The following is a description of a gene set: studied in species Homo sapiens Human Gene Set: GOBP_TRANSLATION The cellular metabolic process in which a protein is formed, using the sequence of a mature mRNA or circRNA molecule to specify the sequence of amino acids in a polypeptide chain. Translation is mediated by the ribosome, and begins with the formation of a ternary complex between aminoacylated initiator methionine tRNA, GTP, and initiation factor 2, which subsequently associates with the small subunit of the ribosome and an mRNA or circRNA. Translation ends with the release of a polypeptide chain from the ribosome., and this is the list of marker genes: MIR27A, WFS1, MRPL49, MIR133B, C8orf88, RPL21, MRPL21, RPL14, OXA1L, MRPS25, PML, MRPL20, MTG2, HBS1L, SMYD5, EIF2B1, TRIM71, CNOT7, FXR1, RPL36AL, MRPL40, CDKAL1, CYFIP1, RPL36, MRPL53, NARS2, EIF3E, MPV17L2, PTRH1, HNRNPU, MIR659, RPL4, RNF139, NCL, TRUB2, AJUBA, MRPL45, RNF14, MIR365A, IARS2, EIF3M, HEMK1, RPSA2, MRPL51, MIR221, KBTBD8, RPL37, CNOT8, LRRC47, BZW1, RPS6KA1, RPS10, CELF4, MIR24-1, FASTKD2, RPS28, SAYSD1, PDF, YARS2, RPS23, EIF2AK3 (eukaryotic translation initiation factor 2 alpha kinase 3), RPL8, SELENOT, EIF1AX, SYNCRIP (synaptotagmin binding cytoplasmic RNA interacting protein), MTPN, RPL39L, RBM4, DHX36 (DEAH-box helicase 36), FAU, PPP1CA, RBMS3, EIF3L, EPRS1, CPEB3, RPL26, EEF1G, MIR17, RPL27A, HRURF, EARS2, LINC01145, DHX33, RPS15, PARP16, MIR205, NAT10, CAPRIN2, MTRFR, MIR29A, PRMT1, RPL30, MRPS16, LARP4B, CDK5RAP3, BZW2, ALKBH5 (alkB homolog 5, RNA demethylase), SKIC8, EIF5B, RNF25, PPP1R15A, EIF2D, MIR128-1, RPL23, MRPL1, ZAR1, GTDC1, EIF2B3, RRBP1 (ribosome binding protein 1), MIR874, LSM14A, RPS29, MRPS31, CPEB1, GEMIN5, SCRIB, RPL37AP8, MTOR, MIR126, ALKBH3, RPUSD3, RPS20, TNF, APEH, RBM4B, CIRBP, MRPL52, FARSB, MRPL33, PYM1, RPS14, ERBB2, RPLP0P6, CELF1, XRN1, IGF2BP2, EIF2AK1, APLP1, MIR379, MAP3K20, UCN, RPS15A, RPS6KB2, MAGOH, DAZ2, RPL28, PIWIL3, ILF3, ASCC3, ELP6, FARSA, EIF3D, NEURL1, BANK1, EIF3C, EEF1B2, RPS6KA3, RPS27L, RPS12, NACA, DUS3L, RPL24, RPSA, MRPL36, MIR877, ELAC1, PIWIL2 (NCBI Gene Id 55124), SHMT1, AKT1, TUFM, QKI, DNAJC1, DHFRP1, ZAR1L, MRPS35 (NCBI Gene Id 60488, mitochondrial ribosomal protein S35), MRPL27, MIR495, RWDD1, B3GNTL1, METTL5 (methyltransferase 5, N6-adenosine), EIF2AK4, JMJD4, YTHDF1, RPS9, MRPL24, MIR214 (microRNA 214), YBX3, RPL22L1, MIR200C (NCBI Gene Id 406985), MIR27B, LARP4, CNOT2, CTIF, RPL17, MAPKAPK5, MKNK2, RPL3, NEMF, MIR106B, CNOT9 (NCBI Gene Id 9125), ASCC2, RPL12, DRG1, RPS27 (NCBI Gene Id 6232), ELP5, IGF2BP1, NSUN3, CALR (NCBI Gene Id 811), PURB, PATL2, RPL9, INPP5E, UNK, EIF5, MIR145, TNRC6B, ALKBH1, LINC02591, DDX6, CAPRIN1 (cell cycle associated protein 1), KRT17, EIF3B, MRPS28, GRB7, EIF1AY, KHDRBS1, RGS2, MRPS15, MIF4GD, MIR96, ACO1, MIR299, EEF1A2, MRPL39, EIF2B4, EEF2, PASK, RPL15, MIR204, EIF3K, DDX1, GSPT2, TCF25, PPP1R15B, YTHDF2, EIF4A1, PRKDC, TNRC6A, OTUD6B, MIR1271, RPL35A, MCTS1, FTSJ1 (NCBI Gene Id 4408), MRPL46, CCL5, MIR20A, RPLP2, RPS27A, AGO2, PSTK, RACK1, MRPL57, RPS24, RPL23A, EIF5AL1, RPL10L, NSUN5, DDX25, TOB1, MIR138-1, USP16, WARS1, UFSP2, MRPL9, MIR503, RPS4Y2, DALRD3, METTL18, SKIC3, TYMS, POLR2G, MIR106A, PUM3, RPL7A, MRPL42, ZCCHC4, ATXN2, HABP4, KARS1, DNAJC3, MIR218-1, GADD45GIP1, IARS1, CASC3, CPEB2, NOLC1, BARHL2, MTIF3, DAZ3, PELO, SERBP1, NGDN, MIR208A, EIF1B, EIF3G, FASTKD3, MRPL48 (mitochondrial ribosomal protein L48), MRPL3, PRKCH, SRP9, MIR212, DDX3X, ELP3, MRPS27, ANKZF1, MIR16-1, IFRD2, AARS2, DHX29, GAPDH, RPS6, PRKCA (protein kinase C alpha), PRR16, LTN1, MRPL55, RIDA, PAIP2, RPS16, CNBP, LIMD1, PADI6, METTL17, FARS2, MRPL10, MIR125B1, SRBD1, ENSG00000293600, RPL18, WARS2, TRNAU1AP, DIO2, EIF4EBP2, RPL13A, YBX2, PCIF1, MIR499A, EFL1 (NCBI Gene Id 79631), DENR, MIR181D, PUM2, MTRF1L, EEF1E1, ZFP36L1, MRPS17, MRPS18C, EIF1, RPL10, RPL13AP3, MARS1, PKP3, RPS25, RARA, ETF1, AGO1, LINC01783 (NCBI Gene Id 100132147), DAPK1, RPS6KB1, SAMD4A, ELP1, ABCE1, MRPS18A, RPS7, AIMP2, RCC1L, ABTB1, IMPACT, MKNK1, MRPL14, AIRE, UQCC2, EIF3H, RPL3L, MIR101-1, EIF2B5, ZFP36, MRPS26, NARS1, PIWIL1, ASMT, MRPL17, GSPT1, RPS3A, SH3BGRL, EEF2K, MRPL44, CARS2, CNOT1, EEF1D, PA2G4, MRPL11, AKT2, EIF4E, MRPL16, YTHDF3, MIR26B, GTPBP1, MRPS11, CNOT6L, BTG2, LSM14B, RPS21, EIF3J, RPUSD4, PIWIL4, RPS26 (NCBI Gene Id 6231), MRPL13, DARS1, HSPB1, NANOS3, EIF4G3, CHCHD1, MIR181A2, MRPL4, MRPL43, RBM24, MRPS5, GATB, THBS1, UBA52, MRPL38, MRPL12, MRPL37, DDRGK1, TARS1 (NCBI Gene Id 94887), PABPC1, MIR483 (NCBI Gene Id 619552), MIR210, RPS2, DHX9, MRPL47 (NCBI Gene Id 57129), MIR520B, GIGYF2, EEFSEC, RPS8, UHMK1, NCK1, MRPL34, RPS11, SARS2, EIF2S1, NPM1, MARS2, PABPC4, UPF3B, MIR148A, DARS2, DAP, RPS19, FXR2, MRPL28, CNOT11, MIR19B1, TARS2, MRPS34, MTFMT, EIF2A, MIR448, KRT13, MRPS2, MCTS2, MRPL54, AURKAIP1, DAZL, DAPL1, MIR98, PTCD3, EIF3F, SARS1, MSI1, TCOF1, RPL29, RPL22, MIR29C, GFM2, SERP1, MIRLET7A1, MRPS18B (mitochondrial ribosomal protein S18B), MIR298, SEPSECS, CSNK2A1, HARS2, MRPS6, RCHY1, ENC1, EIF4E2, EIF3A, NANOS2, RARS1, EIF4E1B, MIRLET7I, MIR346, BOLL, AARSD1 (NCBI Gene Id 80755), MIR100, AARS1, NCK2, TNRC6C, MIR125A, RPS18, MRPS10, HARS1, SSB, RPL6, MRPL35 (NCBI Gene Id 64980), MRPL58, RPL27, EIF5A2, EIF4EBP3, HHEX, PKM, PLXNB2, QRSL1, MIR9-1, MIR141, UPF1 (NCBI Gene Id 5976), LARP1B, RPL10A, MIR1-1, ANG, METTL3, MIR148B, TACO1, RPL32 (ribosomal protein L32), RPL37A, MRPL19, MRPS14, ZNF706, MIR21, BCL3, MIR6086, MIR146A, EPHA4, MIR590, VARS2, LINC03126, LRPPRC, ZCCHC13, SHFL, MTG1, CPEB4, MIR135B, MIR15B, EEF1A1P5, EIF2S3, ELAVL1, WTIP, RPL41, RPL35, MRPL23, QARS1, CSDE1, TPR, SARNP, TRMT10C, ELP4, MIR200B, VARS1, RPS17, MALSU1, EIF4EBP1, EEF1A1, MIR181B1, EIF3CL (NCBI Gene Id 728689), RPL7, YBX1, RPL5, MRPL22, MRPS24, PLD1 (NCBI Gene Id 5337), MIR520C, RPL19, RPL13, DAPK3, EIF2S2, EIF6, DAZ4, MIR144, RARS2, NCBP2, TARS3, EIF2B2, MRPL32, ENSG00000227733, CNOT3, WT1, RPL34, FOXO3, SLBP, TNIP1, PUM1, RBM3, MRPL30, TRAP1, RPL38 (NCBI Gene Id 6169), METAP2, METTL14, USP10, PKP1, LARP6, EIF4G2, UPF3A, ITGA2, PAIP1, HYDIN2, GCN1, APP, COPS5, MIURF, UFL1, RPS3 (NCBI Gene Id 6188), HNRNPD, MIR15A, KLHL25, C1QBP, MRRF, SECISBP2, EIF4ENIF1, MIR107, ZNF385A, EIF4B, MSI2, PURA, MIR28, MRPS23, MIR939, RPL31, RPL39P5, POLDIP3 (NCBI Gene Id 84271), AGO4, RPL39, MIR31, MRPS33, MIR378A, MTRES1, EIF2AK2, GUF1, TIFAB, SHMT2, CARS1, PUS7, LIN28A, SAMD4B (sterile alpha motif domain containing 4B), NMNAT2, MT-TS1, EIF2S3B (eukaryotic translation initiation factor 2 subunit gamma B), MIR29B1, LTO1, RPS5, IGF2BP3, MIR520E, EIF5A, DAP3, TIA1, GTPBP2, EIF4H, MIR132, MIR345, METTL8, LARP1, RPLP1, MRPS22, IL6, RPL11, RPL26L1, RPL36A (ribosomal protein L36a), IGFBP5, MRPS21, RPLP0, ZC3H15, MRPL15, LARS1, MTRF1, PINK1, COA3 (cytochrome c oxidase assembly factor 3), MRPS12, TENT5B, NANOS1, MRPS9, MTIF2 (NCBI Gene Id 4528), GFM1, RPS4X, MRPS7, PRG3 (NCBI Gene Id 10394), SESN2, OGFOD1 (NCBI Gene Id 55239), MIR182, PARS2, TSFM, MRPL2, TRIP4, AGO3, DAZ1, MRPL41, ABCF1, MIR92A1, IREB2, SKIC2, EIF4A3, YARS1, RPS13, EIF3I, CNOT10, OGT (O-linked N-acetylglucosamine (GlcNAc) transferase), RPS4Y1, ATF4, ELP2, FMR1 (NCBI Gene Id 5421), MIR181C, MIR10B, LARS2, NCBP1 (NCBI Gene Id 4686), NIBAN1, TARBP2, CNOT6, EIF4G1, PTCD1, DHFR, EIF4A2, GARS1, MIR134, KLHDC10, RBM8A, DHPS, AIMP1, METAP1, MRPS30, PAIP2B, ZNF540, MRPL18, EIF4E3, TRNT1, NGRN (neugrin, neurite outgrowth associated), CD28, MIR103A1, MRPL50, DRG2, RPL18A, CDK5RAP1, EIF1AD, RMND1, GATC, GZMB, ZNF598